The following is a description of a gene set: Catalysis of the hydrolysis of ester linkages within nucleic acids by removing nucleotide residues from the 5' end. studied in species Homo sapiens Human Gene Set: GOMF_5_3_EXONUCLEASE_ACTIVITY, and this is the list of marker genes: DCLRE1C, XRN1, APTX, CPSF3, TRIR, EXO1, DXO, DCP2, XRN2 (NCBI Gene Id 22803), EXO5, FEN1, PLD4, MGME1, DCLRE1A, DCLRE1B, EXOG, FAN1, PLD3